The following is a description of a gene set: Mouse Gene Set: MIR_7094_1_5P from publication Chen Y, Wang X (PMID 31504780) studied in species Mus musculus Genes predicted to be targets of miRBase v22 microRNA mmu_miR_7094_1_5p in miRDB v6.0 with MirTarget v4 prediction scores > 80 (high confidence targets)., and this is the list of marker genes: Cdhr1, Arhgef37, Tafa1, Ddx19a (DEAD box helicase 19a), Fbxo46, Aak1, Iars2, Tmem35a, Actr3, Arhgap21, Rimbp2, Col25a1, Eya1 (EYA transcriptional coactivator and phosphatase 1), Sf1, Ifi213, Unc5c, Lce3a, Kansl2, Wdr82, Rai14, Zfp963, Osbpl3, Ythdf2, Mob1b, Hspd1, Pag1, Ubxn7, Acox1, Elapor2, Atat1, Zfp65, Tmem170, Wnt2b, Pdzd2, Ccnc, Rph3al, Stag2, Hmgb1, Dock5, Cnot4, 1700066M21Rik, Zfp236, Dad1, Cand1, Il2, Slc7a2, Creb1, Lpin2, Tcf12, Tead1, Sub1, Spice1, Zfp951, Ccdc71, Myh9, Zfp827, Slc10a2, Esr1, Pola1, Arhgef33, Il2ra, Fst, Ret, Trpc4, Zfp738, Orc1, Wtap, Zfp655, Zfp711, Agpat3 (1-acylglycerol-3-phosphate O-acyltransferase 3), Snrnp40, Atxn7, Rfxap, Hypk, Dzip1, AI597479, Lpxn, Dpp10, Diras2, Nipal4, Rpl7l1, Kansl1 (KAT8 regulatory NSL complex subunit 1), Pdp2, Foxo1, Xdh, Foxj3, Mcm6, Ctnnal1, Chac2, Arf3, Pyroxd1, Kcnd2, Zfp493, Trim66, Pkd2l2, Ccdc39, Meioc, Adam22, Alms1, Mrgprx2, Slc4a8, Cdk5rap2 (NCBI Gene Id 72853), Hectd2, Epha3, Ubap1, Dph6, Msl1, Zc3h13, Mpp7, Ing2 (inhibitor of growth family, member 2), Exoc7, 9330159F19Rik, Mmd2, Pals1, Cxcl9, Flvcr2, Atad2, Eif4g3, Fmo5, Farp2, Ank3, Arpc5 (actin related protein 2/3 complex, subunit 5), Slc16a12, Ccnj, Gapvd1, Med30, Sptssb, Esp3, Ahcyl1, Ttc9c, Cntfr, Son, Dcx, Igf1r, Sipa1l3, Nr2e1, Asb1, Gpt2, Col5a2, Csmd3, Nsun4, Ark2n, Phc3, Srsf1, Acad9, Pou3f2, Rem2, Slc39a9, Sorcs1, Suox, Csrp3, Ist1, Plxna1, Rslcan18, Trim33, Chodl, Ddx4, Cast, Sestd1, Aqp9, Psmd11, Ahi1, Ryr3, Ttc9, Naaladl2, Dusp6, Col19a1, Mettl14, Bmpr2, Kcna1, Tmprss13, Cyp3a11, Tmem218, Scamp2, Creg1, Zfp937, Slc25a36, Il17a, Foxk2, Cep350, Qtrt2, Zmym2, Kcnj3, Poc1b, Nufip2, Emc6, Rab9b, Zfp24, Tdrd3, Lpp (NCBI Gene Id 98016), Kpna1, Lamtor3, Btaf1, Slc1a3, Nrbf2, Zcchc13, Atad2b, Plcl1, Cyb561d1, Zfp433, Api5, Zfp729b, Ankub1, Kcnk10